Given this list of marker genes DEDD (death effector domain containing), RRN3P2, IPPK, MYO1C, POLR1C, POLR1A, POLR2E, BNC1, DEK, SPTY2D1, RASL11A, CARM1, POLR1E, DHX33, POLR2F, CREBBP (CREB binding protein), PHF8 (NCBI Gene Id 57793), POLR1F, EIF2AK3, ERCC6, MTOR, BAZ1B, ZMPSTE24 (zinc metallopeptidase STE24), CAVIN1, ERBB2, GTF2H5, TTF1, ATF4, SIRT7, UBTFL1 (NCBI Gene Id 79261), WDR75, HEATR1, RRN3, TAF1, NOP53, TAF1C, PWP1, PIH1D1, NCL, DDX11, SF3B1, ERCC2, TCOF1, POLR1G, SMARCA4, WDR43, DDX21, UBTFL6, GTF2H1, CEBPA, LYAR, NOL11, PRR7, BAZ2A, MACROH2A1, POLR1H, UTP15, TAF1B, MACROH2A2, MARS1, POLR2L, TBP, RRN3P1, SMARCB1, ACTR6, TAF1A, POLR1D, POLR2K, FLNA, MAF1, UBTF, SMARCA5, MYBBP1A, here is a description of the gene set: species: Homo sapiens Human Gene Set: GOBP_TRANSCRIPTION_BY_RNA_POLYMERASE_I The synthesis of RNA from a DNA template by RNA polymerase I (RNAP I), originating at an RNAP I promoter.